The following is a description of a gene set: studied in species Homo sapiens Human Gene Set: REACTOME_REGULATION_OF_MECP2_EXPRESSION_AND_ACTIVITY Regulation of MECP2 expression and activity, and this is the list of marker genes: CAMK2D (calcium/calmodulin dependent protein kinase II delta), AGO3, AURKB, AGO1, HDAC3, TNRC6B, MIR132, MOV10 (Mov10 RNA helicase), NCOR2, CALM1, HDAC2 (histone deacetylase 2), GPS2, HDAC1, TBL1XR1, CAMK4, CAMK2G, CAMK2B, TNRC6A, CREB1, FOXG1, HTT, TNRC6C, AGO2, AGO4, CAMK2A, NCOR1, PRKACA, LBR, SIN3A, TBL1X, MECP2, HIPK2